Given this list of marker genes Ryr3, Med30, Nexmif (NCBI Gene Id 97590), D630045J12Rik, Eeig2, Ufl1, Mstn, Guf1, Chml, Lhfpl3 (NCBI Gene Id 77826), Efcab3, Adamdec1, Rrm2b, Plp1, Thoc1, Rad51, F13a1, Stau1, Cnrip1, Trim41, Inava, Spopfm2 (NCBI Gene Id 100043188), Onecut2, Fkbp14, Ugt8a, Il1rapl2, Palm3, Umps, Bod1l, Rab5a, Bmp5, Ranbp6, Tenm4, Sox2, St6galnac5, Mmp16, Rpp30, Dennd1b, Wnt9a, Ipo8 (importin 8), Pappa2, Rag1, Rbl2, Cox15, Eprs1, Pip4k2a, Cxxc4, Slit3, Fbxw11, Qrfpr (pyroglutamylated RFamide peptide receptor), Atrn, Tfpi, Hnrnpll, Kdm7a, Cltc, Tent5a, Dipk1a, Optn, Pak1, 4930402K13Rik, Tbpl2, Slco1b2, here is a description of the gene set: Mouse Gene Set: MIR_6928_3P studied in species Mus musculus Genes predicted to be targets of miRBase v22 microRNA mmu_miR_6928_3p in miRDB v6.0 with MirTarget v4 prediction scores > 80 (high confidence targets). from publication Chen Y, Wang X (PMID 31504780)